Given this list of marker genes Ncor2, Rac1, Spag9, Syt7, Itsn1, Zer1, Syn2, Kcnj5, Nfya, Tns1, Fbxo41 (NCBI Gene Id 52369), here is a description of the gene set: Abstract: Trastuzumab-induced cardiotoxicity (TIC) is a common and serious disease with abnormal cardiac function. Accumulating evidence has indicated certain non-coding RNAs (ncRNAs), functioning as competing endogenous RNAs (ceRNAs), impacting the progression of cardiovascular diseases. Nonetheless, the specific involvement of ncRNA-mediated ceRNA regulatory mechanisms in TIC remains elusive. The present research aims to comprehensively investigate changes in the expressions of all ncRNA using whole-transcriptome RNA sequencing. The sequencing analysis unveiled significant dysregulation, identifying a total of 43 circular RNAs (circRNAs), 270 long noncoding RNAs (lncRNAs), 12 microRNAs (miRNAs), and 4131 mRNAs in trastuzumab-treated mouse hearts. Subsequently, circRNA-based ceRNA networks consisting of 82 nodes and 91 edges, as well as lncRNA-based ceRNA networks comprising 111 nodes and 112 edges, were constructed. Using the CytoNCA plugin, pivotal genes - miR-31-5p and miR-644-5p - were identified within these networks, exhibiting potential relevance in TIC treatment. Additionally, KEGG and GO analyses were conducted to explore the functional pathways associated with the genes within the ceRNA networks. The outcomes of the predicted ceRNAs and bioinformatics analyses elucidated the plausible involvement of ncRNAs in TIC pathogenesis. This insight contributes to a better understanding of underlying mechanisms and aids in identifying promising targets for effective prevention and treatment strategies. species: Mus musculus from publication Xie S, Zhou N, Su N, Xiao Z, Wei S, Yang Y, Liu J, Li W, Zhang B (PMID 38577019) Mouse Gene Set: XIE_TRASTUZUMAB_CARDIOTOXICITY_MMU_MIR_10A_5P_GENES